The following is a description of a gene set: studied in species Mus musculus The process in which cardiac muscle cell membrane potential changes in the depolarizing direction from the negative resting potential towards the positive membrane potential that will be the peak of the action potential. Mouse Gene Set: GOBP_MEMBRANE_DEPOLARIZATION_DURING_CARDIAC_MUSCLE_CELL_ACTION_POTENTIAL, and this is the list of marker genes: Hcn4, Gja5, Rangrf, Cacna2d1, Cacna1d, Slmap, Scn2b, Scn3b (sodium channel, voltage-gated, type III, beta), Ank3, Scn1b, Cav3, Cacna1c, Scn4b, Scn5a, Trpm4, Cacnb2